The following is a description of a gene set: species: Mus musculus The process of binding or confining calcium ions such that they are separated from other components of a biological system. Mouse Gene Set: GOBP_SEQUESTERING_OF_CALCIUM_ION, and this is the list of marker genes: Ednra, Ccl21e, Gpr39, Gper1, Ero1a, Drd1, Ccl19, Bdkrb1, Nol3 (NCBI Gene Id 78688), Ccl19-ps6, Ryr2, Plcg2, Fkbp1a, Myo5a, Calm2, Cxcl11, Tmem38a, Pde4d, Cd19, Gsto1, Itgb3, Ms4a2, Cxcl10, Ryr3, Jph3, Clec4b1, Plcb1, Jsrp1, Xcl1, Tpcn2, Ptprc, Ccl21a, Ccl19-ps1, Hrc, Sri, Mtln, Prkd1, Trdn, Jph2, Ccl3, Plch1, Gp9, Il13, Chd7, Tgfb2, Itpr1, Diaph1, Casq1, Prkce, Lime1, F2rl3, Ccl19-ps3, Ghitm, Htr2b, Plcl2, Ccl21f, Dmd, Cxcr3, Dbi, Mettl21c, Plcb3, Pdpk1, Lhcgr, Cherp, Gp1ba (glycoprotein 1b, alpha polypeptide), Itgav, Cyba, Psen1, Glp1r, Tgfb1, Anxa6, Plcl1, Pln, Ubash3b, Gp5 (glycoprotein 5 platelet), Slc8b1, Plcb2, F2r, Slc25a23, Cacna1s (calcium channel, voltage-dependent, L type, alpha 1S subunit), Ngf, Htt, Htr2a, Xcr1, P2rx7, Akap6, Plch2, Itpr2, F2, Ccr5, Trpm2 (transient receptor potential cation channel, subfamily M, member 2), Thy1, Drd2, Tmem38b, P2ry6, Casq2, Snca (synuclein, alpha), Ddit3, Calm3, Bax, Plce1, Fgf2, Hap1, Capn3, Fasl, Htr2c, Lck, Gp1bb, Abl1, Ank2, Fkbp1b, Slc8a1, Ryr1, Dhrs7c (NCBI Gene Id 68460), Ccl19-ps4, Itpr3, Cx3cl1, Ibtk, Fcrl5, Cacna1c, Trpc1, Plcg1, Flna, Pkd2, Letm1, Cemip, Npsr1, Atp7b, Ccl19-ps5, Aplnr, Plcb4, Calm1, Camk2d, Gstm7, Ccl21b, Ccl21d, Ntsr1, Selenon, Lyn, Mcoln1, Coro1a, Cxcl9, Ptk2b, Asph, Ptpn6, Atg5